The following is a description of a gene set: Human Gene Set: GSE29615_CTRL_VS_DAY3_LAIV_IFLU_VACCINE_PBMC_DN Genes down-regulated in comparison of peripheral blood mononuclear cells (PBMC) from LAIV influenza vaccinee pre-vaccination versus those at day 3 post-vaccination. Systems vaccinology has emerged as an interdisciplinary field that combines systems wide measurements and network and predictive modeling applied to vaccinology. Here we used the systems vaccinology approach to study the molecular mechanisms underlying the innate responses to the trivalent inactivated influenza (TIV) and live attenuated influenza (LAIV) vaccination in humans, and to identify early gene signatures that predict the magnitude of the antibody responses to influenza vaccination. studied in species Homo sapiens from publication Nakaya HI, Wrammert J, Lee EK, Racioppi L, Marie-Kunze S, Haining WN, Means AR, Kasturi SP, Khan N, Li GM, McCausland M, Kanchan V, Kokko KE, Li S, Elbein R, Mehta AK, Aderem A, Subbarao K, Ahmed R, Pulendran B (PMID 21743478), and this is the list of marker genes: ABLIM1, BBS4, MIPOL1, DDB1, TNFRSF17, CWC27, IDE, MON2 (MON2 homolog, regulator of endosome-to-Golgi trafficking), VPS36, DNAJC16, EOLA2-DT, LINC02012, MTCH2, CRHR2, ABCB10, TUT4, STYX (NCBI Gene Id 730432), IL11, SEC16B, OXCT1, GJA3, SELENBP1, TMX3, H3C11, ZMYND11, DDX60, IPO9, ENSG00000269155, CPE, PPM1L, CALY, NR5A2, ODAD3, UBQLNL, MUS81, DNAAF2, ST6GAL1, SLAMF6, DDX53, IGFBP1, DHX32 (NCBI Gene Id 55760), CMBL, ADRA2A, DECR1, ENSG00000254531, MTIF3, BBS2, LINC01364, CEP350, MNDA, SLAMF9, RASGRP1, CEP290, RBP3, ANKS6, ALG10B, CLEC4F, FLJ13224, PLEKHG6, FTX, LINC00943, MAVS, TRPS1, MACF1, BPNT2, SPG11, ZNF404, PCYOX1, MRPS18B, SNAPC3, VIT, IGSF6, PLAC8, SERPINA7, CABCOCO1, GTF3C2, METTL3, RPGRIP1L, ACBD6, LARP1, LPXN, ARRDC1-AS1, PRDX1, SEC24B-AS1, LRFN1, HMGB4, ATL3 (NCBI Gene Id 283241), LCN12, WDR12, GIMAP2 (NCBI Gene Id 26157, GTPase, IMAP family member 2), RNF111, ISX, HDAC11, MRPS31, NDUFA8, OGG1, KASH5, PREPL (prolyl endopeptidase like), DDX17, GTF2E1, XPO1, DNAAF10, CEP126 (NCBI Gene Id 57562), AQR, STING1, RANBP3L, ELAVL1, MEIS3, CTNNBL1, CLCN3, TRAF5, POLK, ARX, RPL13P5, DKKL1, CHCHD4, KLHDC7A, KRTAP7-1, C5orf15, RAG1, SF3B3, TRAC, SLC7A1, NPAS3, ALYREF, IGLV3-19, RNF145, GJB5, HSD17B4, TREM2, GARIN2, SYNRG, KRTAP4-8, PROCA1, ADAM30, PDCD6IP (programmed cell death 6 interacting protein), MFSD8, NEK2-DT, GJB1, ZKSCAN1, BBS7, CHMP3, ECH1, RNF170, KLHDC3, DKK4, SPCS3, OIP5-AS1, PTCD2, IQSEC2, VEPH1, ANGEL2, TRG-AS1, ITK, TRADD, ZNF512, IL27RA, PDCL2, WNT2B, XRCC5, RNF151, IRGM, DNAJC13, COASY, DUSP15, LNPEP, C6orf62, PANK3, TDH-AS1, SRSF1, TNPO2, CASP6, PPP2R1A, FAM163A, CFAP298, PRKACB, SETD5, SAMD13, CLEC2D, TTC9B, LAMA4, AP3D1, FAM170B, FTO, DNAJC24 (DnaJ heat shock protein family (Hsp40) member C24), LACRT, BRS3, FAM215A, GCFC2, RTCB, CFAP210, LY6E-DT (NCBI Gene Id 84963), CARNMT1, YWHAEP7